Given this list of marker genes XPC (XPC complex subunit, DNA damage recognition and repair factor), CX3CL1, PRKAA2, TNFRSF10B, PTEN, IRF5, PRKAB2, DDB2, NOTCH1, BAX (BCL2 associated X, apoptosis regulator), MIR200C, DDIT4, BTG2, SERPINE1, ISG15, APAF1, ACAD11, SIVA1, SAT1, AURKA, FAS, ICAM1, TP53INP1, TIGAR, PRKAG1, THBS1, TNFRSF10D, NANOG, MIR34A (microRNA 34a), SFN, CCNG1, CCNE1, RPRM, MGMT, FUCA1, LIF, PMAIP1, PERP, SESN2, PCNA, MIR145, PRKAG3, NCF2, PML, CPT1C, FASLG, MIR34B, CCL2, MLST8, ULK2, MLH1, TSC2, MTOR, GADD45A, BBC3, MSH2 (mutS homolog 2), IRF9, CDC25C, CDK2, TNF, SCO2, PRKAB1, PIDD1, ULK1, CDC25A, POLK, ULBP2, DEPTOR, FANCC, TP53I3, DRAM1, RPTOR, ZMAT3, ADGRB1, ADORA2B, PRKAA1, GLS2, SLC7A11, E2F7, RRM2B, TRAF4, TP53AIP1, ALDH4A1, SESN1, SERPINB5, AKT1S1, GPX1, SMR3B, ERCC5, MIR34C, XRCC5, POLH, CDKN1A, PRKAG2, SLC2A1, ULBP1, here is a description of the gene set: Human Gene Set: WP_P53_TRANSCRIPTIONAL_GENE_NETWORK species: Homo sapiens p53 transcriptional gene network